The following is a description of a gene set: species: Homo sapiens Human Gene Set: HP_DELAYED_CNS_MYELINATION Delayed CNS myelination Delayed myelination in the central nervous system., and this is the list of marker genes: LMX1B, ALG14, PGAP1, PIGS, AP3D1, RNF13, HNRNPC, RHOBTB2, SLC1A2, NRCAM, ZFX, NADK2, POLR2A, CNOT3, SLC1A4, TPR, EXOC8, LIPT1, ACY1, UBA5, NACC1 (nucleus accumbens associated 1), NAE1, DDX6, FANCB, RAP1GDS1, ARX, PPP2R1A, RERE, PIGU, COPB2, POU3F3, C18orf32, FZR1, FBXO28, TMEM240, EXOSC2, TMEM147, EARS2, MDH2, SLC16A2, CHAMP1, MTHFS, HMBS, SLC19A1, KCNC2, NGLY1, CLPB, RFX7, CUL3, SIN3A (NCBI Gene Id 25942), KDM1A, WARS2, TMEM163, ALDH7A1, ALG13, WARS1, U2AF2, CACNA1I, ARID1B, RAB3GAP1, GOLGA2, SLC6A1, PLAA, ELOVL4, PRUNE1, BRAT1, AHDC1, GABRG2, ZNF148 (zinc finger protein 148), MLYCD, ITPA, BCS1L, PHACTR1, FRMPD4, AIFM1, FOXP1, ZNF335, GNB2, PKDCC, MORC2, ZNF526, TRNT1, GNAO1 (NCBI Gene Id 2775), TNPO2, POLR3B, ADAT3, YME1L1, FOXG1, D2HGDH, RBM8A, FAR1, TRAPPC2L, POGZ, CTNNB1, FCSK, RAB11B, NMNAT1, ATP6AP2, INTS11, HCFC1, CLCN7, PIBF1, SMG9, DHX30, GLS, CLTC, YY1, MMUT, KIF5A, TGFB1, GRIK2, FRMD5 (NCBI Gene Id 84978), EXOSC1, NUP133, ZC4H2, KCNT1, TNR, TRMT5, ATP1A3, UFC1, SMPD1, PPP2CA, GET4, SLC2A1, TRIM8, DOHH, H4C5, AARS1, SLC12A5, VPS11, TAF13, PPP3CA, CDK19, PLPBP, PEX7, ZMIZ1, NUP188, CARS1, DNM1L, TBC1D24, FANCL, EIF2AK2, SHANK3, STXBP1, HIKESHI, YRDC, NEDD4L, GLYCTK, LIPT2, TXN2, CLCN3, ASH1L, TRRAP, GTF2H5 (general transcription factor IIH subunit 5), PRMT7, MADD, FBXL4 (F-box and leucine rich repeat protein 4), RNU7-1, AFG2A, TAF2, ATP9A (NCBI Gene Id 654090), ARF1, MED17, TIMM22, UPB1, ALG9, ACTL6B, HS2ST1, SLC35A2, ARNT2, PURA, SETD1A, SCO2, KIDINS220, FOCAD, GEMIN4, CDC40, KCNH5, NIPBL, VPS33A, SLC35B2, COG3, EZH2, PPIL1, ADARB1, TMEM106B (transmembrane protein 106B), UGDH, MPV17, NCDN, NRROS, RNU4-2, ALDH6A1, ALDH5A1, DHX37, BMP4, CLTCL1, NEUROD2, NARS1, TMEM63A, ALG2, WWOX (NCBI Gene Id 9621), IER3IP1, KCNN2, TKFC